The following is a description of a gene set: species: Homo sapiens Reactome Pathway: Biofilm formation part of: Infection with Enterobacteria Irreversible attachment of E.coli to host and other surfaces is the prerequisite for the change of the motile to a sedentary phenotype. This in turn is followed by the production of a complex mature biofilm, resulting in increased resistance towards host defenses and antimicrobial agents. In the last stage, biofilms support the release of new motile bacteria. The biofilm matrix mainly consists of polysaccharides like cellulose and colanic acid, held together by specific adhesins like curlin and Ag43., and this is the list of marker genes: UPK1A, fimH, FN1, COL4A5 (NCBI Gene Id 1287), LAMA5, COL4A6, COL5A3, LAMB3, LAMC1, bcsC, LAMA4, LAMA3, bcsA, EPCAM, COL4A2, bcsQ, bcsB, bcsG, LAMB2, COL5A1, LAMC3, papGI, COL4A4, COL4A1, csgA, mrkD, sfaS, LAMA1, LAMC2, yhjR, LAMA2, LAMB1, draE, bcsE, COL4A3, COL5A2